The following is a description of a gene set: Human Gene Set: HP_NARROW_FORAMEN_OBTURATORIUM species: Homo sapiens Narrow foramen obturatorium Decreased width of the foramen obturatorium. The foramen obturatorium (also known as the obturator foramen) is a hole located between the ischium and pubis bones of the pelvis., and this is the list of marker genes: CCN2, CCR6, IRF5, HLA-DRB1, KIAA0319L, CAV1